The following is a description of a gene set: from publication Lang R, Pauleau AL, Parganas E, Takahashi Y, Mages J, Ihle JN, Rutschman R, Murray PJ (PMID 12754506) species: Homo sapiens Genes up-regulated in macrophages: untreated versus IL6 for 400min. Human Gene Set: GSE411_UNSTIM_VS_400MIN_IL6_STIM_MACROPHAGE_UP Effects of SOCS3 on the transcriptional response of bone marrow-derived macrophages to IL-6. Fetal liver cells from SOCS3+/+ or SOCS3-/- embryos were used to reconstitute recipient mice. Donor derived bone marrow from these mice was differentiated to macrophages. Macrophages were either unstimulated, or stimulated for 100 or 400 minutes with 10 ng/ml IL-6., and this is the list of marker genes: NUP42, TMCC2, KANSL2, PPM1E, C2orf42, GPAT3, MRPS31, MIGA2, DTWD1, TRIM45, EXOSC7, ZKSCAN8, CAMTA1, STAM, SEPHS1, SLC20A2, MICAL1, NAB1 (NCBI Gene Id 4664), TOR3A, RPAP1, LCOR, H2BC13, HMG20A, APH1B, FEM1A, METTL14, CHAMP1, SAMD10, CCDC28A, GLO1, CAMKMT, SMUG1, GCFC2, TRIM44 (NCBI Gene Id 54765), METTL1, MYBBP1A, MRM3, ZNF862, FLACC1, GANC, PEX2, TMEM100, IFT70A, PIGP, PIGV, RAP1GAP, PARL, GML, ZC3H6, TARDBP, TOR1B, ZNF623, SLFN13, NOPCHAP1, AMIGO1 (adhesion molecule with Ig like domain 1), TTC28, OVCA2, C2orf49, MPZL3, MBD1, CCDC71, POLR1E, VPS54, METAP1D, RUNDC3B, C3orf33, ARHGAP24, FOXRED2 (FAD dependent oxidoreductase domain containing 2), LMBR1, DGLUCY, CTNNA1, TCEA3, BTBD19, CYLD, DDX5, ERN1, OAS2, ARL14EP, C4orf33, ARHGAP18, BCL2L2, AKAP7, TRUB1, TRNAU1AP, COPS7A, PLXND1, MIOS, EARS2, TBC1D23, RAB12, MAST4, BID, TRUB2, ZNF124 (zinc finger protein 124), BST1 (bone marrow stromal cell antigen 1), LPAR6, ANGEL2, KLHL22, CHST14, MTAP, OOSP2, DTD2, MGST1, AMN1 (antagonist of mitotic exit network 1 homolog), GLCE, NDUFAF1 (NCBI Gene Id 51103), SRM, MAP3K5, RNF130, NUMA1, RNF187, COASY (NCBI Gene Id 80347), YTHDF2, SLC12A7, RGS3, COPG2, HS3ST3B1, CHPT1, FCMR, STARD6, GALNT4, AS3MT, DHODH, CCDC115, CYB561D1, TFDP2, GPR160, NUDT12, PCYOX1, PLPP3, SLC35A1, ZNF229, TIGAR, MTG2, PCTP, ABCC5, FUBP3, ADPRM, C19orf48P, ZNF383, MTHFD1, TUBGCP5, ZNF354B, FGFBP3, ZNF566, NSG2, GCOM1 (GCOM1, MYZAP-POLR2M combined locus), IL15RA, TYSND1 (trypsin like peroxisomal matrix peptidase 1), PRRC1 (proline rich coiled-coil 1), ACP6, MOGS, WDR12, DENND6B, ANAPC4, CPT2, ADORA3, TET1, IDNK, ELK3, C17orf75, TBC1D5, CFP, STEAP4, CNR2, FBXW10, TRMT6, STARD5 (StAR related lipid transfer domain containing 5), C2CD2, KLF13, AMER1, LRTM2, BBS4, COQ2, MRPS2, PTCD3, SLC22A3, WDR6, DOK3, LGALS3BP, EID1 (NCBI Gene Id 27110), COPS7B, MAGEH1, AHI1, TANGO2, FAF2, ACSF2, ARFIP2, AKR7A2, WWOX, AFP, NAE1, PLPP6, EHBP1 (NCBI Gene Id 23301), ZNF14, ZBTB45, RCN1, SMYD2, IPCEF1, ZNF395